The following is a description of a gene set: species: Homo sapiens Human Gene Set: GOBP_PIGMENT_BIOSYNTHETIC_PROCESS The chemical reactions and pathways resulting in the formation of a pigment, any general or particular coloring matter in living organisms, e.g. melanin., and this is the list of marker genes: SLC24A5, ABCB10, RAB38, FLVCR1, DDT, TMEM14C, RPE65, TSPO, DCT, FXN, COX15, CDH3, ZEB2, GIPC1, ALAS2, PMEL, UROD, MC1R, CPOX, RAPGEF2, SRRD, PGRMC1, ALAS1, ASIP, MFSD12, SLC45A2, SLC25A38, ALAD, IREB2, TYRP1, ATP7A, OPN3, GPR143, ATP5IF1, COX10, TMEM14EP, HMBS, CITED1, TMEM14DP, OCA2, TMEM14A, TMEM14B, WNT5A, UROS, TRPC1, SLC11A2, SLC7A11, ABCB6, PPOX, TYR, SLC6A9, NFE2L1, FECH, APPL1, IBA57, CTNS, SLC25A39, ABCB7